Given this list of marker genes XRCC6P4, NKAIN3, RNU6-596P, RPL26P26, CERNA3, RNA5SP266, ENSG00000254006, RPL7L1P18, MOS, TARDBPP4, ENSG00000253281, PPIAP85, NASPP1, RNU4-50P, MIR4470, RAB2A, SNORD54, SBF1P1, RNA5SP265, ENSG00000253871, LINC01289, TMEM68, ENSG00000254775, GGH, SEPTIN10P1, YTHDF3-DT, IFITM8P, YTHDF3, ENSG00000253857, UBXN2B (NCBI Gene Id 137886), RN7SKP97, TTPA, RPL30P10, PDCL3P1, RN7SKP135 (RN7SK pseudogene 135), CA8, CLVS1, BHLHE22, C1GALT1P3, SDR16C6P, SLC2A13P1, LINC01301, TOX, SDR16C5, CYP7B1, XKR4, FAM110B, LYN, RN7SL135P, LINC02842, SNORA1B, ASPH, CHD7, LINC01414, PTPN11P2, LINC00588 (NCBI Gene Id 26138), MIR124-2, ENSG00000294233 (NCBI Gene Id 105375845), ENSG00000253205, XKR4-AS1, COX6CP8, BPNT2, LINC01606, PENK, RPS20, NPM1P21, ENSG00000254055, TGS1, RN7SL798P, ENSG00000253614, SRPK2P, CYP7A1, NSMAF, SDCBP, LINC03018, LINC01602, RNA5SP267, BHLHE22-AS1, RPL37P6, NPM1P6, KRT8P3, CHCHD7, MIR124-2HG, TOX-DT, NARS1P2 (asparaginyl-tRNA synthetase 1 pseudogene 2), LINC00968, PENK-AS1, ENSG00000206853, RN7SL323P, RNU6-13P, PLAG1, IFITM3P8, here is a description of the gene set: Human Gene Set: chr8q12 species: Homo sapiens